The following is a description of a gene set: The directed movement of substances along cytoskeletal fibers such as microfilaments or microtubules within a cell. species: Mus musculus Mouse Gene Set: GOBP_CYTOSKELETON_DEPENDENT_INTRACELLULAR_TRANSPORT, and this is the list of marker genes: Klc2, Ift20, Ssna1, Map6, Ppfia2, Stau2, Ccdc88b, Bicd1, Kif21b, Armcx3, Hspa8, Wdpcp, Atg16l1, Myo19, Arl3, BC048507, Fyco1, Mgarp, Wasl, F8a, Bicdl1, Ap3d1, Spg11, Kif16b, Ap3s2, Camsap3, Bbs1, Cnih2, Bloc1s5, Bloc1s1, Terf2, Sun2, Ccdc186, Rab1a, Tmem230, Ttc21b (NCBI Gene Id 73668), Dync1h1, Ift57, Hook1, Daw1 (dynein assembly factor with WDR repeat domains 1), Nde1, Rpgr, Nefl, Bloc1s4 (biogenesis of lysosomal organelles complex-1, subunit 4, cappuccino), Ift27, Ift43, Hspb1, Sun1 (NCBI Gene Id 77053), Spg7, Bsn, Kif17, Map6d1, Kif2a, Map1a, Kif3a, Ccdc38, Ttc21a, Klc1 (NCBI Gene Id 16593), Nme7, Dync1i2, Arl8a, Hook3, Copg2, Wasf1, Rhot1, Bicdl2, Dync1i1, Lca5l, Pcm1, Pura, Kif21a, Ift88, Ap3b2, Prkcz, Hsbp1, Kif1c, Actr10 (ARP10 actin-related protein 10), Dynlt2b, Mapt, Borcs6, Ift122, Ift81, Spast, Ift70a2, Ccdc88c, Dlg2, Agbl4, Bloc1s6, Wdr35, Trim46, Cep131, Borcs5, Myrip, Sfpq (NCBI Gene Id 78315), Stau1, Cln3, Ccdc88a, Kif1b, Dtnbp1, Sod1, Kif5b, Kifc2, Uchl1, Wdr19, Stk11, Dst, Kif28, Map1b, Ift140, Fez1, Lca5, Cluap1, Hif1a, Tanc2, Copg1, Ift74, Mreg, Bloc1s2, Arl8b, Rabgef1, Kif3b, Snapin, Nefh, Trak2, Rhot2, Lamp1, Mecp2, Htt, Dynll1, Mak, Myo1c, Ift80, Fnbp1l, Flot2, Ift52, Hnrnpu, Clip3, Syt4, Tmem108, Borcs8, Dync2li1, Neto1, Ift22, Actn4, Syne2, Map2k1, Klc3, Madd, Kif5a, Bbs12, Dync2i2, Tmem201, Ap3m1, App, Ift56, Cdc42, Kxd1, Kifc1, Hap1, Ift70b, Dync2h1, Ndel1, Kif13a, Hook2, Ap3m2, Kifap3, Trak1, Ank3, Cilk1, Ubb (ubiquitin B), Ap3s1 (adaptor-related protein complex 3, sigma 1 subunit), Rab21, Dync2i1, Hdac6, Spag17, Pex14, Rab27b, Myo5a, Mapk8ip3, Rab17, Traf3ip1, Bloc1s3, Prickle1, Myo10, Sybu, Agtpbp1, Map2, Fuz (fuzzy planar cell polarity protein), Ift70a1, Kifbp, Bicd2, Nefm, Tub, Fbxw11, Pafah1b1, Rasgrp1, Tuba1a, Kif1a, Ssx2ip, Ift172, Trim58, Borcs7, Kif5c, Ift46, Caly, Arhgap21, Intu, Atg5, Ift25, Ap3b1